The following is a description of a gene set: Mouse Gene Set: GOCC_SPECIFIC_GRANULE studied in species Mus musculus Granule with a membranous, tubular internal structure, found primarily in mature neutrophil cells. Most are released into the extracellular fluid. Specific granules contain lactoferrin, lysozyme, vitamin B12 binding protein and elastase., and this is the list of marker genes: Clcn3, Anxa11, Crisp1, Stx3 (NCBI Gene Id 20908), Stxbp3 (syntaxin binding protein 3), Stxbp2, Anxa3, Camp, Snap23, Olfm4, Adam8, Ltf, Vamp1, Stx4a